The following is a description of a gene set: Human Gene Set: MIR3194_5P from publication Chen Y, Wang X (PMID 31504780) species: Homo sapiens Genes predicted to be targets of miRBase v22 microRNA hsa-miR-3194-5p in miRDB v6.0 with MirTarget v4 prediction scores > 80 (high confidence targets)., and this is the list of marker genes: SOX21, FUT1, LAMP5, C15orf39, PIGN, GSG1L, ARID4B, NEUROG2, DOK4, DNAJB2 (DnaJ heat shock protein family (Hsp40) member B2), CNST, TRAF1, ZNF516, METTL21A, CRISP3, NAA25, GMEB2, LRRC10B, ATP8A2, ORAI2, IRAK3, USP49, CCT7, RALB, GRSF1 (NCBI Gene Id 2926), LUZP1, TNRC6B, TBC1D16, DMTF1, KHDC4, PAFAH1B1, MEAK7, MICAL3, ARNT (aryl hydrocarbon receptor nuclear translocator), TXLNA, C10orf62, CAPRIN1, C1QTNF5, ATP1A3, MYO1E, TXNDC8, IRF5, DYNLL2, DICER1, TOX, TBC1D26, UHMK1 (NCBI Gene Id 127933), ARSD, NEURL2, CAB39, ADAMTS17, TMSB4Y, HECTD4, TMSB4X, PAXBP1, SGCD, ABCB9, MAP7, SOS1, GPAM, GABBR2, DYNLT5, LARP4, ACTG1, SMIM17, ZBTB43, EFCAB11 (NCBI Gene Id 90141), TMEM179, ELF5, NCDN, ATPAF2, EBPL, MEAF6 (MYST/Esa1 associated factor 6, NCBI Gene Id 64769), SYBU, PPP3R1, CKAP4, SYPL2